Given this list of marker genes Ccl24, Atp5f1b (ATP synthase F1 subunit beta), Calr, Naa20, Lrpprc, Septin11, Socs6, Dok2, Hspe1, Atp5mc1, Cltc, Ahnak, Tsfm, C3, Mgl2, Fabp5, Serbp1, Casp6, Batf3 (basic leucine zipper transcription factor, ATF-like 3), Chil3, Mrc1, Ranbp1, Nsun2, here is a description of the gene set: Cytokines mediate cell-cell communication in the immune system and represent important therapeutic targets. A myriad of studies have highlighted their central role in immune function, yet we lack a global view of the cellular responses of each immune cell type to each cytokine. To address this gap, the authors created the Immune Dictionary, a compendium of single-cell transcriptomic profiles of more than 17 immune cell types in response to each of 86 cytokines (>1,400 cytokine-cell type combinations) in mouse lymph nodes in vivo. A cytokine-centric view of the dictionary revealed that most cytokines induce highly cell-type-specific responses. For example, the inflammatory cytokine interleukin-1β induces distinct gene programmes in almost every cell type. A cell-type-centric view of the dictionary identified more than 66 cytokine-driven cellular polarization states across immune cell types, including previously uncharacterized states such as an interleukin-18-induced polyfunctional natural killer cell state. species: Mus musculus Mouse Gene Set: CUI_MONOCYTE_IL13_RESPONSE_UP from publication Cui A, Huang T, Li S, Ma A, Pérez JL, Sander C, Keskin DB, Wu CJ, Fraenkel E, Hacohen N (PMID 38057668) Genes positively differentially expressed in cell type: Monocyte upon treatment with cytokine: IL-13 in mouse lymph nodes in vivo.